The following is a description of a gene set: UDP-derived sugars synthesis in fibroblasts Human Gene Set: WP_UDPDERIVED_SUGARS_SYNTHESIS_IN_FIBROBLASTS studied in species Homo sapiens, and this is the list of marker genes: PGM1, HK3 (hexokinase 3), GPI, GFPT1, PGM3, GCK, UXS1, UGDH, HK1, HK2, GALE